The following is a description of a gene set: Midostaurin, also known as PKC412, is a type I tyrosine kinase inhibitor with activity against FLT3. This pathway describes FTL3 mutants that are resistant to inhibition by midostaurin. Reactome Pathway: midostaurin-resistant FLT3 mutants species: Homo sapiens part of: Drug resistance of FLT3 mutants, and this is the list of marker genes: FLT3